Given this list of marker genes Cop1, Gstp1, Jund, Jun, Ccrl2 (NCBI Gene Id 73654), Avpi1, Uba52, Hspa1a, Coq10b, Neat1, Ddx5, Pmaip1, Fos, Nr4a1, Trappc5, Ccr9, Dnajc7, Btg2, Tra2a, Mef2c, Stap1, Nfkbiz, Ifrd1, Kmt2c, Il1b (interleukin 1 beta), Gsr, Tcf4, Smad7, Egr1, Ccnl1, Septin6, Atf3, Tbc1d4, Klf2, Tnip3, Kdm6b, Cd209e, Rasgrp2, Cd7, Ppp1r15a, Rhob, Junb, Cd209a, H1f2, Fosb, Dusp1, Nav1, Stk17b, Nedd4, Nfkbia, H3f3b, Ier2, Nktr, Jup, H2-Oa, L1cam, Samsn1, here is a description of the gene set: from publication Cui A, Huang T, Li S, Ma A, Pérez JL, Sander C, Keskin DB, Wu CJ, Fraenkel E, Hacohen N (PMID 38057668) Genes negatively differentially expressed in cell type: cDC2 (conventional dendritic cell type 2) upon treatment with cytokine: AdipoQ in mouse lymph nodes in vivo. Mouse Gene Set: CUI_CDC2_ADIPONECTIN_RESPONSE_DN Cytokines mediate cell-cell communication in the immune system and represent important therapeutic targets. A myriad of studies have highlighted their central role in immune function, yet we lack a global view of the cellular responses of each immune cell type to each cytokine. To address this gap, the authors created the Immune Dictionary, a compendium of single-cell transcriptomic profiles of more than 17 immune cell types in response to each of 86 cytokines (>1,400 cytokine-cell type combinations) in mouse lymph nodes in vivo. A cytokine-centric view of the dictionary revealed that most cytokines induce highly cell-type-specific responses. For example, the inflammatory cytokine interleukin-1β induces distinct gene programmes in almost every cell type. A cell-type-centric view of the dictionary identified more than 66 cytokine-driven cellular polarization states across immune cell types, including previously uncharacterized states such as an interleukin-18-induced polyfunctional natural killer cell state. species: Mus musculus